Given this list of marker genes HIF3A, RXRA, RHOT2, ING1, MDM2, CCND1, CDKN2C, CUX2, NFATC3, CDC25A, CENPF, CUL4B, ACVR1B (NCBI Gene Id 93351), here is a description of the gene set: Genes up-regulated in 293 cells (embryonic kidney) expressing polymorphic variants S427G (SNP ID=rs2070235) or I624M (SNP ID=rs11556379) of BMYB. species: Homo sapiens from publication Schwab R, Bussolari R, Corvetta D, Chayka O, Santilli G, Kwok JM, Ferrari-Amorotti G, Tonini GP, Iacoviello L, Bertorelle R, Menin C, Hubank M, Calabretta B, Sala A (PMID 18026132) The B-MYB proto-oncogene is a transcription factor belonging to the MYB family that is frequently overexpressed or amplified in different types of human malignancies. While it is suspected that B-MYB plays a role in human cancer, there is still no direct evidence of its causative role. Looking for mutations of the B-MYB gene in human cell lines and primary cancer samples, we frequently isolated two nonsynonymous B-MYB polymorphic variants (rs2070235 and rs11556379). Compared to the wild-type protein, the B-MYB isoforms display altered conformation, impaired regulation of target genes and decreased antiapoptotic activity, suggesting that they are hypomorphic variants of the major allele. Importantly, the B-MYB polymorphisms are common; rs2070235 and rs11556379 are found, depending on the ethnic background, in 10-50% of human subjects. We postulated that, if B-MYB activity is important for transformation, the presence of common, hypomorphic variants might modify cancer risk. Indeed, the B-MYB polymorphisms are underrepresented in 419 cancer patients compared to 230 controls (odds ratio 0.53; (95%) confidence interval 0.385-0.755; P=0.001). This data imply that a large fraction of the human population is carrier of B-MYB alleles that might be associated with a reduced risk of developing neoplastic disease. Human Gene Set: SCHWAB_TARGETS_OF_BMYB_POLYMORPHIC_VARIANTS_UP